Given this list of marker genes Psmd12, Psma7, Pdia3, Ubac1, Lnpep, Fbxl16, Herc2, Ube2s, Cdc26, Rnf114, Klhl25, Fbxo2, Ube2o, Ubc, Lonrf1, Socs3 (suppressor of cytokine signaling 3), Psmb6 (proteasome (prosome, macropain) subunit, beta type 6), Asb11, Elob, Uba52, Ube2m, Hecw2 (HECT, C2 and WW domain containing E3 ubiquitin protein ligase 2), Mylip, Npepps, Dtx3l, Klhl42, Asb12, H2-M10.2 (NCBI Gene Id 333715), H2-Q1 (NCBI Gene Id 15006), Fbxw5, Psma2, Psme2b, Fbxo10, Asb4, Trim21, Rnf19a, Asb14, Lrr1, Psmc1, Psmb2, Rnf182, Asb13, Cyba (NCBI Gene Id 13057), Klhl41, Asb6, Thop1, Rnf217, Klhl3, Ubr4, Skp1, Ube3b (NCBI Gene Id 117146), Spsb4, Fbxo7, Cdc27, Nedd4, Uba5, Btbd1, Pja1, Fbxl3, Cd207, Tap1, Psma3, Asb17, Cul7, Ube2j1, Sec24a, Vhl (NCBI Gene Id 22346), H2-Q2, Asb1 (NCBI Gene Id 98461), H2-T10, Znrf2, Klhl13, Ube2q2, Smurf2, Atg7, Fbxw17, Psmb8, Znrf1, Rbck1, Anapc1, Ube2d3, Uba7, Ubox5, Anapc2, Fbxo44, Uba3, Rnf111, Hace1, H2-Q4, Fbxo32, Kbtbd8, B2m, Cdc20, Rnf123, Ubr2, Arel1, Sar1b, Ube2l3, Klhl21, Fbxo15, Herc4, Sec13, Fbxo27, Cdc34, Rbbp6 (retinoblastoma binding protein 6, ubiquitin ligase), Lrrc41, Stub1, Rnf25, Sh3rf1, Psmd14, Fbxl20, Fbxl4, Trip12, Psmd6, Wwp1, Sec24d, Rnf144b, Fbxl14, Kctd7, Cdc23, Ube2q1, Ube2n, Mrc1, Herc1, Fbxl7, Trim50, Ube2e1, Psma4, Cul1, Herc6, Sec23a, Psmd7, Asb7, Socs1, Klhl11, Kbtbd13, Psma1, Snap23, Erap1, Asb10, H2-M3, H2-Q7, Bcap31, Siah1a, Fbxw10, Ube2j2, Rnf4 (ring finger protein 4), Psmd3, Prkn, Trim36, Psma5, Trim11, Rnf213, Fbxo22, Fbxo11, Anapc10, H2-M10.1, Asb18, H2-T22, Keap1, Uba1, H2-Q10, Ube2v1, Mex3c, Tpp2, Ube2e2, Vamp3, Fbxl19, Trim9, Itgav, Asb16, Psmd8, Ube2d2a, Traip, Rnf126, Cblb, Psmb4, Klhl5, Ube3a, Sec22b, Psme2, Mkrn1, H2-M10.4, Fbxo17, Psmc5, Psmb3, Rps27a (NCBI Gene Id 78294), Fcgr1, Siah2, Rnf130 (ring finger protein 130), Hspa5, Fbxo40, Cul2, Wsb1, Fbxl12, Ube4a, Anapc11, Sec24c, Ncf1 (neutrophil cytosolic factor 1), Fbxo21, Ufl1, Psmc6, H2-T23, H2-M5, Rchy1, Fbxo31, Hectd2 (NCBI Gene Id 226098, HECT domain E3 ubiquitin protein ligase 2), Ube2k, Ube2w, Asb9, Cybb, Fzr1, Anapc7, Psmc2, Psme1, Nedd4l, Canx, Anapc13, Psmb10, Rlim, Psmc3, Trim71, Spsb2, Ube2g1, Klhl9, Unkl, Ube2c, Spsb1, Uba52rt, Klhl22, Fbxo4, Psmb7, Rnf41, Trim39, H2-M9, Lrsam1, Trim32, Ube2a, Blmh, Ncf2, Btbd6, Psmd2, Psmc4, Ltn1, Fbxl15, Fbxw2, Ncf4, Rnf6, Ubb, Fbxo6, Cdc16, Ube2h, Trim41 (NCBI Gene Id 97771), Psmb5, Herc3, Arih2, Fbxo30, Mrc2, Stx4a, H2-M10.5, Sec24b, Ube2v2, Uba6, Fbxw8, Calr, Ube2r2, Ube3c (ubiquitin protein ligase E3C), Hectd1 (NCBI Gene Id 320157), Gan, Itch, Ube2e3, Asb5, Cd36, Trim69, Fbxl8, H2-K1, Fbxl13, Rnf34, Fbxl18, Ube2l6, Glmn, Ube2g2, Psmd13, Klhl20, Psmb1 (NCBI Gene Id 98079), Kctd6, Anapc5, Huwe1, Trim37, Fbxl21, Mib2, Asb8, Fbxw9, Rnf19b, Ube3d, Tap2, Lnx1, Rnf7, Adrm1, Fbxl5, Eloc, Fbxo41, Rbx1, H2-M1, Vamp8, Dcaf1, H2-M11, Det1, Rnf115, H2-Q6 (NCBI Gene Id 636948), Pja2, Ube2b, Rnf220, Cul3, Traf7, H2-M2, Rnf138, Ube2z, H2-M10.6, Psma6 (proteasome subunit alpha 6), Sec31a, H2-M10.3, Fbxo9 (NCBI Gene Id 71538), Rnf14, Hectd3, Smurf1, Fbxw7, Mgrn1, Ccnf, Fbxw4, Tapbp, Ubr1, Psmd1, Lmo7, Fbxw11, Klhl2, Kbtbd7, Ube2d1, Psmd11, Skp2, Dzip3, Anapc4, Cbll1, Ube2f, here is a description of the gene set: Mouse Gene Set: REACTOME_CLASS_I_MHC_MEDIATED_ANTIGEN_PROCESSING_PRESENTATION Class I MHC mediated antigen processing & presentation species: Mus musculus